The following is a description of a gene set: species: Mus musculus Genes predicted to be targets of miRBase v22 microRNA mmu_miR_7676_3p in miRDB v6.0 with MirTarget v4 prediction scores > 80 (high confidence targets). Mouse Gene Set: MIR_7676_3P from publication Chen Y, Wang X (PMID 31504780), and this is the list of marker genes: Frat1, Pkd2l2, Slc28a1, Aifm2, Csnk1d